Given this list of marker genes PIGY, EFNB1, DPH2, ZFX, GATA1, STX16, KMT2A, PTDSS1, ADA, TCF12, GGCX, PPM1D, HRAS, POP1, CNOT2, TFAP2B, TFAP2A, PPP1CB, SDHD, CBL, DOCK6, COL11A1, PIGS, COL2A1, PRDM16, ARHGAP31, AFF4, NIN, BBS2, RPL15, WNT7A, SALL4 (NCBI Gene Id 57167), CHRNA7, PTHLH, LSS, GNB2, LHX3, BICRA, RAF1, REV3L, TNNT3, IQSEC2, WNT4, DNMT3A, ADNP, ESCO2, SLC26A2, CLCN7, PALB2, LUZP1, USF3, HESX1, CWC27, TAF6, TBX1, FLNB, PHF6, DVL3, TELO2, EVC2 (NCBI Gene Id 132884), RYR3, SCN2A, OBSL1, RPS17, ZMYM2, RHOA, PIGP, FANCC, PROP1, DYNC2H1, RPL10, KAT6B, SMC3, IL7R, PIK3R1 (phosphoinositide-3-kinase regulatory subunit 1), SEMA3E, EDA2R, HHAT, HMGA2, NPHP1, SPECC1L, DHODH, NLRP3, ARID1A, MAP3K7, DYNLT2B, CITED2, MAFB, VPS35L, MBD5, RAD51C, IFT27, RPS28, KCNAB2, SIL1, KCNN3, KCNH1, TOPORS, RMRP, LTBP1, FANCD2, ASPH, LONP1, CHSY1, FGF9, EPB41L1, ERI1, ZFPM2, ARL6 (NCBI Gene Id 84100), SIK3, BBIP1, SF3B4, GATA5, JAG1, CUL4B, RTL1, AP1G1, PCYT1A, TTC21B, SMARCB1, MACROH2A1, RAP1B, SUFU, GJA1, RBPJ, ALMS1, UBE4B, PAX3, SMARCD1, LIG4, ARSL, ARX, BBS1, PGAP3, MMP23B, SOS2, FAM149B1, RBM8A, COMP, CPLX1, SH3PXD2B, PRKAR1B, DPYSL5, SLC2A1, LMNB2, MIR17HG, SOS1 (NCBI Gene Id 7838), GNAS, PIGO, IFT80, GABRD, ACP5, RBBP8, DHCR7, DCLRE1C, RIN2, LTBP3, POGZ, AHSG, LETM1, CHRNA1, CHST11, BMP2, PDE3A, DYNC2I1, MRAS, PSMD12, ZBTB20, PAH, FAM20C, HBA1, ACAN, RPL5, LRP4, WDR19, PIGG, SLC32A1, RPL8, ASXL1, C12orf57 (NCBI Gene Id 113246), POU1F1, ALOX12B, WDPCP, DONSON, KIF7, CHD7, ZDHHC9, RPS29, RPL35 (ribosomal protein L35), FBN1, CEP55, BCR, FTO, TAF1, RLIM, SRCAP, KDSR, SHOX, KDM6A, RPL31, RRAS2, RPS7, ACTL6B, TMEM231, ADAMTS10, FBXO28, PTCH2, RPL18, PLXND1, BBS5, IFT43, EBF3, RDH11, LTBP2, FN1, PAPSS2, CTSK, RAB23, WDR35, SEC23B, SCN1B, ROR2, HUWE1, CDH11, RPL27, CEP290, CSGALNACT1, GPC4, GJA8, MTOR, MIA3, EOGT, HOXA13, TBX22, CTCF, RPL35A, ALG6, RAB3GAP2 (RAB3 GTPase activating non-catalytic protein subunit 2), CUL7, GJB4, FLI1, NFIX, IFT172, PCNT, MRPS16, NXN, PIGW, RPL11, HBA2, PIK3CA, PDPN, SDCCAG8, TRIM8, KCNA1, NIPBL, MYMK, KLLN (NCBI Gene Id 100144748), BMPR1B, ANTXR2, NSUN2 (NCBI Gene Id 54888), MASP1, SETBP1, ADA2, TBX3 (T-box transcription factor 3), FGFR3, NBAS, COX4I1, LBR, SIN3A, SMARCC2, NEXMIF, PIGQ, NOTCH2, RAD21, DVL1, EDA, BBS4, RPS19 (NCBI Gene Id 8378), HDAC8, TRIM32 (NCBI Gene Id 3971), DPF2, CRIPT, BBS10, CEP19, COG4, TPR, ATP7A, NELFA, PIGB, GRIP1, WDR11, MIR140, WIPI2, SMARCE1, SLX4, PRKAR1A, FLNA, PIGN, LZTR1, TMEM216, SCLT1, POLA1, TWIST2, DCPS, MAF, SKI (NCBI Gene Id 6497), KCNK4, PTPN11, CASK, PGM3, FGF10, SMARCA2, PDE4D (phosphodiesterase 4D), KAT6A, RIPK4, PLAG1 (NCBI Gene Id 7996), GRIN1, MYMX, SLC25A24, MECOM, IL2RG, SLURP1, PIGA, RERE, IFT74, SNX14, FAM111A (FAM111 trypsin like peptidase A), IARS2, FANCA, DDR2, GNAO1, FGFRL1 (fibroblast growth factor receptor like 1), BRAF, TBL1XR1, TSR2, CSPP1, GDF5, CDKN1C, FBXW11, DYNC2I2, RSPRY1, ZMIZ1, ABCA12, GATA4, EIF4A3, GMNN, NPR2, CEP120, MGP, MSX2, RAC1 (NCBI Gene Id 5879), CASZ1 (castor zinc finger 1), RPS27, BHLHA9, RPS24, PIGF, NOTCH1, SLC25A22, HEATR3 (HEAT repeat containing 3), BBS7, AKT1, HDAC4, SMG9, PITX1, BGN (biglycan), GPC3, PPOX, KCNJ2, CCDC22, PDGFRB, CHST3, MKKS, CHRND, EXOSC2, MED12, B3GLCT, SOX4, RPS10 (ribosomal protein S10), CHN1, ALG8, ZNF699, COL10A1, RAG2, AHDC1, ERF, DEAF1, ATRX, PTH1R, RPL9, RAG1, KIAA0753, BPNT2, SPEN, IHH, SMC1A, RPS6KA3, CREBBP, PPP3CA, APC, NEUROD2, TRPV4 (transient receptor potential cation channel subfamily V member 4), RPS15A, KMT2D, SHOC2, PUM1, CRKL, RPS26, DYRK1A, HNRNPR, TGDS, PRKACB, POC1A, WASF1, NEK1, WNT5A (NCBI Gene Id 7474), IGF2 (NCBI Gene Id 492304), BBS9, GDF6, CPLANE1 (ciliogenesis and planar polarity effector complex subunit 1), ARID2, NSD2, GLI3, CILK1, KNSTRN, MYSM1, LMNA, MAP2K1, TRPM3, CAMK2G, MGAT2, SLC35C1, FGD1, RUNX2, BRCA2, PTEN, HS2ST1, FGFR2, SCAPER, TTC8, CFAP418, TASP1, RB1, KDM1A, LHX4, DLK1 (delta like non-canonical Notch ligand 1), EHMT1, GLI1, CTBP1, NOG, RASA2, POR, ARID1B, BAP1, GJB3, KIAA0586, EXT1, BMP4, MARS1, SPART, MKS1, SCUBE3, NKX2-6, GJA5, NKX2-5, ZMPSTE24, SLC35D1, PIK3C2A, KRAS, EXTL3, FANCE, STAMBP (NCBI Gene Id 10617), ALX1, FLII, GNPNAT1, HOXD13, FANCI, TBC1D24 (TBC1 domain family member 24), IFT122, NEPRO, COL11A2, MEGF8, DYNC2LI1 (NCBI Gene Id 51626), LIFR, ACVR1, GHR, PIGL, GPX4, LZTFL1, INTU, GATA6, MBTPS1, RPL26, SMAD4, PDE6D, AIFM1, CANT1, APC2, GRB10, TLK2, FLT4, MEIS2, PNKP, TBX15, KLF13, ROBO1, DBH, PRKACA, SDHC, BRF1, VAC14, CDKL5, ITGB6, RECQL4, TRPS1, TBX5, SOX11, WAC (WW domain containing adaptor with coiled-coil), MAPK1, FZD2, RNU4ATAC, ALX3, DDX3X, SVBP, PUF60, PIK3CD, INPPL1, CHRNG, BRD4, TONSL, TWIST1, PGAP2, KIF26A, ASAH1, RIT1, TCTN3, PRKCZ, ADAMTS17, GRM7, UBE2T, SPRED2, UBAP2L, MAGEL2, EVC, PNPLA6, CDC42BPB, PRKG2, GNAS-AS1, MYCN, KCNJ8, IFT140, ABCC9 (ATP binding cassette subfamily C member 9), EIF2AK3, BCOR, HSPG2, KDM5C, RAI1, LAMA5, CCDC32, PIGV, GDF1, SNRPN, MEG3, ATP6V1B2, PRMT7, EP300, RRAS, TGFBR2, MAPK8IP3, ADAMTS2, POMP, SIK1, FANCF, FGFR1, YY1AP1, MCTP2, RPS20, DMXL2, KDR, IFT57, SDHB, PTCH1 (NCBI Gene Id 8015), BBS12, TMEM67, CSNK2A1, PIGK, TRIP11 (NCBI Gene Id 9321), CBFB (NCBI Gene Id 9163), CEP152, OFD1, SMARCD2, IGF1R, CCDC28B, PORCN, NRAS, PLCB3, DLL4, FIG4 (FIG4 phosphoinositide 5-phosphatase), DYM, UPF3B, ASCC3, SOX9, IFT81, PKDCC, KIF15, WASHC5, BRIP1, ALOXE3, FTSJ1, TRIO, IFT52, SCNM1, ZIC1, IRX5, SMARCA4, here is a description of the gene set: studied in species Homo sapiens One or more digit that appears disproportionately short compared to the hand/foot, whereby either the entire digit or a specific phalanx is shortened. Human Gene Set: HP_SHORT_DIGIT Short digit